Given this list of marker genes Pmaip1, Btg2, Zfp36l2, Stk17b, Rgs2, Mmp9, here is a description of the gene set: Genes negatively differentially expressed in cell type: Neutrophil upon treatment with cytokine: IL-15 in mouse lymph nodes in vivo. from publication Cui A, Huang T, Li S, Ma A, Pérez JL, Sander C, Keskin DB, Wu CJ, Fraenkel E, Hacohen N (PMID 38057668) studied in species Mus musculus Cytokines mediate cell-cell communication in the immune system and represent important therapeutic targets. A myriad of studies have highlighted their central role in immune function, yet we lack a global view of the cellular responses of each immune cell type to each cytokine. To address this gap, the authors created the Immune Dictionary, a compendium of single-cell transcriptomic profiles of more than 17 immune cell types in response to each of 86 cytokines (>1,400 cytokine-cell type combinations) in mouse lymph nodes in vivo. A cytokine-centric view of the dictionary revealed that most cytokines induce highly cell-type-specific responses. For example, the inflammatory cytokine interleukin-1β induces distinct gene programmes in almost every cell type. A cell-type-centric view of the dictionary identified more than 66 cytokine-driven cellular polarization states across immune cell types, including previously uncharacterized states such as an interleukin-18-induced polyfunctional natural killer cell state. Mouse Gene Set: CUI_NEUTROPHIL_IL15_RESPONSE_DN